Given this list of marker genes Lsm4, Rbm8a, Hnrnpu, Sf3b6, Cdc5lrt9, Dhx16, Mettl14, Nol3, Khdrbs3, Clns1a, Scaf11, Nup98, Cenatac, Psip1, Rbmx2, Dhx8, Aqr, Ddx17, Srsf1, Slu7, Ddx39a, Upf3b, Arb2a, Cwc22rt4, Rbm41, Rbm44, Esrp2, Pqbp1, Ddx5, Zbtb7a, Fbxo24, Smu1, Slirp, Thrap3, Ppil1, Arglu1, Ilf3, Gemin2, Cdc5lrt6, Magoh, Rbm7, Fra10ac1, Esrp1, Gemin4, Zmat2, Mfap1b, Snrnp25, Rbm10, Cwc22, Rbmyf1, Rbm6, Tssc4, Ik, Cdc5lrt4, Magohb, Wdr77, Tdrd6, Fmr1, Snu13, Wdr83, Paxbp1, Gemin8, Mbnl2, Zrsr2, Crnkl1, Srsf5, Obi1, Celf3, Cwc22rt7, Hspa8 (heat shock protein 8), Cdc5lrt5 (cell division cycle 5 like, retrotransposed 5), Prmt7, Srrm2, Srsf10 (serine and arginine-rich splicing factor 10), Rbm47, Lsm3, Yju2 (NCBI Gene Id 72886), Srpk3, Txnl4a, Rbm11, Rbm42, Cdk13, Hnrnpc, Mbnl1, Tra2b, Prpf3, Celf6, Gemin5, Rnf113a1, Sf3b3, Sf3b2, Sfpq, Snrpd1, Rbfox3, Ubl5, Lmntd2, Snrpe, Cdc5lrt10, Luc7l3, Srsf2, Prpf38a, Cdc5l, Cirbp, Sf3b1, Sf3a1, Snip1, Cwc22rt3, Prpf8, Cwc22rt6, Malat1, Hnrnpul2, Larp7, Dazap1, Cwc15, Celf1, Cdc5lrt7, Ptbp3, Rbfox1, Rbm4, Snrpert, Cwc22rt1, Sde2, Rbm20, Ddx23, U2af1, Prpf31, Hnrnpul1, Casc3, Wtap, Cwc22rt5, Yju2b, Ints15, Akr1c6, Phf5a, Cwf19l1, Rnpc3, Gemin7, Cwc22rt2, BC005624, Nova1, Usp39, Hnrnpa2b1, Snrpf, Thumpd2, Snrpn, Rbm14, Rbm39, Ythdc1, Rbm15, Hmx2, Gpkow, Ddx39b, Plrg1, Sart1, Tia1, Zfp64 (NCBI Gene Id 22722), Dcps, Cwf19l2, Srsf4, Prpf39, Usp49, Mettl16, Upf1, Jmjd6, Srrm1, Snrpa1, Rbmxl1, Snrpa, Rbpms2, Rbfox2, Snrnp200, Rbm8a2, Sf3b5 (splicing factor 3b, subunit 5), Ppie, Lsm7, Lsm2, Ctnnbl1, Cdc40, Usp4 (NCBI Gene Id 22258), Snrpc, Lsm5, Gemin6, Prpf40a, Prpf19 (NCBI Gene Id 28000), Ptbp2, Larp7-ps, Wbp4, Slc39a5 (NCBI Gene Id 72086), U2af2, Ncl, Hnrnpa3 (heterogeneous nuclear ribonucleoprotein A3), Snrpd3, Khdrbs2, Srsf6, Prpf4b, Luc7l2, Xab2, Eif4a3, Strap, Bud13, Bud31, Srsf8, Smn1, Prpf4, Rbm3, Ptbp1, Mfap1a, Cdc5lrt8, Ddx42, Snrnp35, Sap18, Eftud2, Celf4, Son, Celf2, Ddx41, Dbr1, Rbm22 (RNA binding motif protein 22), Celf5, Zcrb1, C1qbp, Rbm17, Rbm25, Sap18b, Setx, Isy1, Ess2, Nova2, Acin1, Srrm4, Cwc25, Sart3, Npm1, Rbmxl2, Gpatch8, Htatsf1, Ddx20, Srsf9, Rbmyf3, Pcbp4, Syf2, Rnps1, Snrpg, Eif4a3l1, Gcfc2, Sf3a3, Rsrc1, Rsrp1, Sf1, Snrpb, Prdx6b, Rbpms, Sf3a2 (NCBI Gene Id 20222), Txnl4b, Rbmyf9, Rbm5, Rbm24, Ddx46, Tfip11, Srsf12, Sfswap, Coil, Snw1 (NCBI Gene Id 66354), Zc3h14, Dnajc17, U2af1l4, Srpk1, Rest, Dhx40, Srpk2, Snrpb2, Exosc10, Rnf113a2, Rbm15b, Snrpd2, Ncbp2, Aar2, Khdc4, Mettl3, Gemin6-ps, Cactin, Prpf6, Snrnp70, Hnrnpa1, Tra2a, Hnrnpm, Myod1 (NCBI Gene Id 17927), Dhx9, Khdrbs1, Eif1, Lsm8, Dyrk1a, Prdx6, Rbmy, Ncbp1, Ubl5b, Bcas2, Cdc5lrt1, Sf3b4, Gm7324, Srsf7, Upf3a, Rbmx, Prpf18, Qki, Scnm1, Prmt5, Hnrnpk, Srsf3, Eif4a3l2, Dhx38, Lsm6, Hnrnpl, Luc7l, Puf60, Nsrp1, Prpf40b (NCBI Gene Id 78333), Rbmyf6, here is a description of the gene set: Mouse Gene Set: GOBP_RNA_SPLICING_VIA_TRANSESTERIFICATION_REACTIONS Splicing of RNA via a series of two transesterification reactions. studied in species Mus musculus